Given this list of marker genes Tspo, Ndrg1, Aldh2, Cp, Atf3, Cdsn, Trib3, Gpr137b (NCBI Gene Id 97883), Ptgr1, Prrx1, Gtf3c5, Gast, Twist2, Prr13, Nqo1, Anxa8 (NCBI Gene Id 218906), Ephx1, Cck, Rnd2 (NCBI Gene Id 11858), Ptgfr, Sec61a1, Ptges, Acaa2, Rbp1, Tnxb, H2-T23, Cd34, Car6 (NCBI Gene Id 12353), Itgb7, here is a description of the gene set: from publication Berenjeno IM, Núñez F, Bustelo XR (PMID 17213802) We have used microarray technology to identify the transcriptional targets of Rho subfamily guanosine 5'-triphosphate (GTP)ases in NIH3T3 cells. This analysis indicated that murine fibroblasts transformed by these proteins show similar transcriptomal profiles. Functional annotation of the regulated genes indicate that Rho subfamily GTPases target a wide spectrum of functions, although loci encoding proteins linked to proliferation and DNA synthesis/transcription are upregulated preferentially. Rho proteins promote four main networks of interacting proteins nucleated around E2F, c-Jun, c-Myc and p53. Of those, E2F, c-Jun and c-Myc are essential for the maintenance of cell transformation. Inhibition of Rock, one of the main Rho GTPase targets, leads to small changes in the transcriptome of Rho-transformed cells. Rock inhibition decreases c-myc gene expression without affecting the E2F and c-Jun pathways. Loss-of-function studies demonstrate that c-Myc is important for the blockage of cell-contact inhibition rather than for promoting the proliferation of Rho-transformed cells. However, c-Myc overexpression does not bypass the inhibition of cell transformation induced by Rock blockage, indicating that c-Myc is essential, but not sufficient, for Rock-dependent transformation. These results reveal the complexity of the genetic program orchestrated by the Rho subfamily and pinpoint protein networks that mediate different aspects of the malignant phenotype of Rho-transformed cells. Genes up-regulated in NIH3T3 cells (fibroblasts) after treatment with Y27632, an inhibitor of ROCK proteins; the changes did not depend on expression of constitutively active (Q63L) form of RHOA. Mouse Gene Set: BERENJENO_ROCK_SIGNALING_NOT_VIA_RHOA_UP species: Mus musculus